Given this list of marker genes Ctnnbip1, Cntn2, Slmap, Nwd2, Api5, Celsr2, Elavl2 (NCBI Gene Id 15569), Agps, 2810459M11Rik, Wee1, Esam, Chsy1, Gabra4, Cog6, Epc1, Zfp770, Tfpi2, Frk, Hoxd13, Tmem168, Pcnx1, Tbc1d19, Osbpl11, Kdm6a, Fam171b, Ap4s1, Pax9, Shroom2, Bag4, Pakap, Cgn, Cyria, Gpcpd1, Ankhd1, Zfand6, Atg4c, Scai, Vps37a, Igsf1, Tmx4, Armcx2 (armadillo repeat containing, X-linked 2), Gga3, Cd28, Plekhg4, Pcmtd2, Asxl1, Lasp1, Dmtf1l, Cnn1, Tfdp1, Ocln, Sfrp4, Agpat5, Stag1, Pygo2, Tmem248, Fam168b, Bcl6, Cacnb2, Ncam2, Phf6, Oscar, Cd2ap (NCBI Gene Id 98065), Trim16, Dpysl2, Nacc2, Mex3b, Prkcsh, Edem3, Phaf1, Ppp2r1b, Hacd4, Dio1, Med13, Fam118b, Mcf2, Ugt2b5, Ccdc96, Marchf9, Chd2, Bend4, Nos1ap, Zfp92, Rfx6, Onecut2, Naa40, Stim2, Zc3h11a, Chmp5, Rnd3, Dab2, Zmym4, Vamp1, Jag1, here is a description of the gene set: Mouse Gene Set: MIR_125B_2_3P from publication Chen Y, Wang X (PMID 31504780) Genes predicted to be targets of miRBase v22 microRNA mmu_miR_125b_2_3p in miRDB v6.0 with MirTarget v4 prediction scores > 80 (high confidence targets). studied in species Mus musculus